The following is a description of a gene set: studied in species Mus musculus Mouse Gene Set: GOBP_BONE_RESORPTION The process in which specialized cells known as osteoclasts degrade the organic and inorganic portions of bone, and endocytose and transport the degradation products., and this is the list of marker genes: Idua, Oscar, Cyp19a1, Dlk1, Ihh, Adrb2 (adrenergic receptor, beta 2), Pth1r, Tfrc, Csk, Egfr, Car2, Rab7, Tnfrsf11b, Il20ra, Rac2, Tcirg1, Acp5, Traf6 (NCBI Gene Id 99098), Itgb3, Adam8, Slc4a2, Gpr137b, Il6, Ctsk, Rac1, Lrp6, Cldn18, Ubash3b, Syk, Cd38, Fshb (follicle stimulating hormone beta), Trf, Iapp, Nf1, Vegfa, Ctss (NCBI Gene Id 13040), Bbln, Tpp1, Cartpt, Rufy4, Calcr, Inpp5d, Tns3, Il7, Siglec15 (NCBI Gene Id 639725), Fcgr4, Spp1, Dcstamp, Tmem64, Ncdn, Gpr137, Pdk4, Nox4, Src, Ahsg, Prkca, P2rx7 (NCBI Gene Id 18439), Rab3d, Gpr55, Tnfrsf11a, Itgav (NCBI Gene Id 76358), Tmem119, Hamp, Ccdc154, Ppargc1b, Ctnnb1, Arap1 (NCBI Gene Id 69710), Tnfsf11, Def8, Enpp1, Ext1, Csf1r, Ptger4, Ptk2b, Hnf1a, Cbl, Lrrk1, Ltbp3, Fshr, Ceacam1, Snx10, Plekhm1, Mc4r, S1pr1